The following is a description of a gene set: species: Mus musculus Human Gene Set: MEISSNER_BRAIN_HCP_WITH_H3K4ME3_AND_H3K27ME3 from publication Meissner A, Mikkelsen TS, Gu H, Wernig M, Hanna J, Sivachenko A, Zhang X, Bernstein BE, Nusbaum C, Jaffe DB, Gnirke A, Jaenisch R, Lander ES (PMID 18600261) DNA methylation is essential for normal development and has been implicated in many pathologies including cancer. Our knowledge about the genome-wide distribution of DNA methylation, how it changes during cellular differentiation and how it relates to histone methylation and other chromatin modifications in mammals remains limited. Here we report the generation and analysis of genome-scale DNA methylation profiles at nucleotide resolution in mammalian cells. Using high-throughput reduced representation bisulphite sequencing and single-molecule-based sequencing, we generated DNA methylation maps covering most CpG islands, and a representative sampling of conserved non-coding elements, transposons and other genomic features, for mouse embryonic stem cells, embryonic-stem-cell-derived and primary neural cells, and eight other primary tissues. Several key findings emerge from the data. First, DNA methylation patterns are better correlated with histone methylation patterns than with the underlying genome sequence context. Second, methylation of CpGs are dynamic epigenetic marks that undergo extensive changes during cellular differentiation, particularly in regulatory regions outside of core promoters. Third, analysis of embryonic-stem-cell-derived and primary cells reveals that 'weak' CpG islands associated with a specific set of developmentally regulated genes undergo aberrant hypermethylation during extended proliferation in vitro, in a pattern reminiscent of that reported in some primary tumours. More generally, the results establish reduced representation bisulphite sequencing as a powerful technology for epigenetic profiling of cell populations relevant to developmental biology, cancer and regenerative medicine. Genes with high-CpG-density promoters (HCP) bearing histone H3 dimethylation at K4 (H3K4me2) and trimethylation at K27 (H3K27me3) in brain., and this is the list of marker genes: TBX3, ROR2, SLC16A3, CDH22, OSR2 (odd-skipped related transciption factor 2), PCDH8, MOB3B, MAFB, DNAAF6, NPR3, HRH1, ASS1, MYO16, METRN, CPT1A, SLC7A2, HTR1B, FZD6, NTN4, EBF1, ANTXR2, TBX2, PAQR9, ITPKA (NCBI Gene Id 3706), SYNE3, HRH3, VAT1L, CHST8, SLCO5A1, SLC16A12, ECT2, MAL, AFAP1L2, TENM4, FOXD1, ANXA2, EN1 (engrailed homeobox 1), SLC25A13 (solute carrier family 25 member 13), ZIC5, SPIDR, NFE2L2, ADGRG6, SHISA2, IGDCC3, OPRD1, EDARADD, SYPL2, SOX18, ARHGAP11A, SMAGP, PRODH, SLC13A3, BMP6, IGFBP5, IGFBP4, TACR3, KIT, CXCL14, SP5, AMIGO2, DBX2, GJD2, GNAS, SHC4, IGFBP7, WNT10A, SLC25A21, LAMC2, CIMIP3, EGR2, SCN4B, CIMAP1B, SYT6, RCSD1 (RCSD domain containing 1), BUB1, NFIX, MLKL (mixed lineage kinase domain like pseudokinase), CBFB, SWAP70, MMP23B, TFCP2L1, HHEX, C1QL2, TWIST2, NEFH, TNFAIP8L3, CLDN5, SH3PXD2A, POPDC3, PLPP3, PAWR, PENK, PTPN14 (protein tyrosine phosphatase non-receptor type 14), CNN2, FGF5 (NCBI Gene Id 9192), IL17RB, RALYL, FGF11, ADAMTSL5 (NCBI Gene Id 339366), DPYSL5, RAP1GAP2, SALL3, VSIG10, GALNT6, TSKU, SELENOV, ADA, PLEKHF1, PAX3, EPB41L1, SLC9A3, GHSR, QRFPR, CAVIN1, SNX7, ARHGEF26, HLX, ACP7, VIM, SLC12A7, P2RX2, ADRA2A, NELL1 (NCBI Gene Id 4745), CRACR2B, RGS6, KIF18B, ID3, NKX1-2, GALR1, SHROOM3, PARP14, TENT5B, CPXM1, NKX3-1, SATB1, AP1M2, TPBG, NIFK, ASAP3, MDFIC, IRX5, NR4A2, SNX22, VIPR2, CDC42EP1, HS3ST2, GJB6, PAX6, CSPG4, BACE2, UTRN, IRS4, GLIS1, SMTNL2, GLIPR2, MAP3K6, FHDC1, FOXC1, PLTP, UBE2C, GJB2, CXADR, HES1, NFATC2, SEMA3F, LRRK1, ATP12A, SOX7, PTGER4 (prostaglandin E receptor 4), STXBP6, WRAP73, CARD10, GLI2, NTSR1, MOXD1, NEUROD2, ABT1, LY75, RGS7BP, KCNJ6, NRIP3, DCXR, SLC9A2, USP18 (ubiquitin specific peptidase 18), SLC16A9, ADAMTS15, GYPC, ATP1B1, EBF2, LIN7A, WNT6, SLC22A3, SDC1, TEAD4, GLDN, KCNK13, TC2N, PDE9A, GCH1, ITPR3, TXNIP, DLL3, KCNS3, GXYLT2, ABAT (NCBI Gene Id 731754), BFSP1, HHIP, ALOX12, PMP22, FREM2, LPCAT2, PROKR2, NOTUM, SVEP1, BOLL, SOX21, BARX2, BDNF, PPM1L, ANLN, PHLDB2, GNG13, IGF2BP2, HTRA1, SLC27A2, TBR1, KCNJ4, NHERF1, KCNF1, TCF7L2, SCIN, ACER2, KITLG, CCN1 (NCBI Gene Id 3491), CCND1, SNTB1, TES, TRIM36, SFI1, FOXF2, PODXL, NAPRT, OAF, DDIT4L, CCDC125, ID4, TMC6, SHISA6, COA6, PRDM8, IGSF21, ONECUT1, ZFP36L2, ISL2, PIF1, MTUS1, SCUBE2, DOCK1, COL26A1, CARTPT, SLC32A1, NEUROD1, FZD2, ECHDC2, TRIM47, DAB2, CPNE2 (NCBI Gene Id 8903), LITAF, THSD7B, PLCG2, MCUB, CCDC102A, A4GALT, ATOH8, RASSF7, RGS10, WWTR1, STAT5A, CBLN2, DOK1, MBNL3, DUSP10, GPR150, SNAI1, UNC5B, ASIC2, ITGA9, EBF3, DIPK1C, HK2, DYSF, KIAA1217, SORCS2, FGFR2, PTH2, AP1S3, MYB, EYA1, PODN, VAV2, CBS, N4BP3, C1orf115, PKDREJ, SYT2, HCN4, FAM110C, PDE4A, GFRA1, PROX1, LOXL4, NXN, LHFPL6, DLX1, CXCL16, NUAK2, EFNA5, ADRA1B, ASCL1, PIMREG, PDE5A (NCBI Gene Id 8654), KIRREL2, ATF3, DLC1 (DLC1 Rho GTPase activating protein), PPP1R1B, SEMA5B, EMILIN2, POU3F2, ABTB2, C1QTNF4, GAS1, CCNO, ST8SIA2, BCL2L11, FGFR3, ALS2CL, E2F2, CCBE1, ICAM5, WNT1, PDGFRA, PRKCZ, CH25H, TUBB6, FOXF1, ADRA1D, PTHLH, SLC43A1, TTK, GIPC3, ERICH2, GALR3, PRR5L, FBLN7, STK32A (serine/threonine kinase 32A), COL12A1, NXNL2, TGFB1, MLXIPL, GAB1, TSPAN12, DUSP4, DOCK8, JAG1, IL4R, PLEKHG3, SLC35D3, AREG, HS3ST3B1, CGNL1, VGF, STAC, PRSS12, SATB2, SLC4A4, RRM2, ZIC2, TMEM108, ITPRIPL2, CNIH3, AHNAK, KLK8, MCIDAS, KCNH8, RUNX1, RSPO2, IL17RD, NID2, ASCL2, COL27A1, ADRA2B, PXDC1, PTPRK, PIK3AP1, SDC4, CRTAC1, KDELR3, PLXNA4, AIF1L, FLVCR2, ACE, TRIL, VAMP5, NME2, SPRY4, FOXL2, RBPMS2, CMTM7, OLIG2, NEUROG2, KCNK6, BMP7, MBOAT1, PPM1J, KCTD1, STOM, CTSH, PRKCH, CHRNB2, NR2E1, GLIS3, ATP7B, BAG3, CNKSR3, RNF152, SYNGR3, PLEKHA2, PDLIM5, PLAG1, GRID2IP, AVPR1A, SULF2, PRKG1, RIPPLY3, SOWAHB, ITGA4, CRYBA2, PDLIM1, MTFR2, CD63, SGO1, GPC5, SALL1, GAD2, MKX, LHX2, KANK4, MMP28, TBX18, BCAR3, NPNT, ADORA2B, CRISPLD2, TUBA1C, PRRG4, PTPRB, ATP6V1C2, SLC16A10, EGFLAM, HIC1, GAD1, HEYL, PTPN5, NECTIN2, KCNQ2 (potassium voltage-gated channel subfamily Q member 2), IL17RA, CD24, HTR7, NFE2L3, KISS1R, NRG3, PIK3R5, PTPRU, GPRC5C, DAPK2, SCARA3, VAX1, HMCN1, CBLN4, PDE10A, RELN, ADAMTS8, ROR1, EGFR, CLIC5, TRIM14, NFIB, C6orf141, MFSD2A, NRARP (NOTCH regulated ankyrin repeat protein), THEMIS2, SLC6A11, PRKCQ, LTB4R2, ELFN1, ATP8B1, MARVELD3, SLC24A4, CCDC3, CASZ1, FLI1, PRSS23, LEF1, PDE1B, PTGER3, SOX1-OT, RAB11FIP1, SIX3, EFHD1, SCN5A (NCBI Gene Id 652341), ITGA5, UNC13B, C1QL1, ABTB3 (NCBI Gene Id 440109), OSMR, SLC29A4, MYCN, PPL, NDRG2 (NDRG family member 2), VSTM4, LAMA1, ACSF2, PRDM1, NPR1, C4orf19, INA, TRHDE, VIPR1 (vasoactive intestinal peptide receptor 1), SCUBE3, ABLIM3, NKX6-2, SYT13, ST14, KCNH3, FST, SLC1A3, EMB, CD302, CEMIP, ITGB5, NIBAN1, MCAM, KDR, MAL2, ADAMTS5, ARHGAP29, CSRP2, KCNK9, PPARA, CGAS, L3MBTL4, RGS9BP, CWH43, MOCOS, MAFF, DHRS3, OXTR, KCNA3, RHOC (NCBI Gene Id 389), ARX, TEC, ZNF804A, CMTM8, F3, PMAIP1, HS3ST6, ADGRE5, SCUBE1, WNT11, EIF4EBP1, WNT9A, B3GAT2, NXPH3, ADRB2, RET, EDN3, SYNGR2, CFAP206, RASGRF1, RNF220, DPP10, ARHGEF17, HTR2C, TSPAN18, SIGIRR, LOX, PKP2, GPR139, NTF3, KCNA7, HTR1F, MGAT5B, FUT4, SLC6A1, NKD2, EPHA2, SLC30A3, S1PR1, ANO5, TRIM58, PTGER2, TPM1, SLC30A10, CCN2, KCNK12, SLC39A8, TMEM37, NODAL, DMRTA2, CFAP299, SLC13A5, TBX15, FBXL7, TP53I11, MYO10, NTN1, CPNE7, CCDC88C, GREM1, FOSL1, TSPAN15, SEMA3C, LGR5, MDGA1, COLEC12, CDK18, DLL4, RPRM, HTRA4, SMO, ANO1, INHBB, EPHA3, TOP2A, KLHL14, WNK4, RBPMS, LDLRAP1, RERG, ZBTB7B, H1-5, TMEM63A, CD9, FOXP4, GPR83, FXYD6, BMP2, EGR3, P2RY1, PLOD2, HS3ST5 (heparan sulfate-glucosamine 3-sulfotransferase 5), CDCA7, WNT4, FHL3, E2F7, PTPN18, OTX2, PTGIS, PRLHR, MINAR1, MAP3K20 (mitogen-activated protein kinase kinase kinase 20), LMO1, KLF4, TICRR, STRIP2 (NCBI Gene Id 57464), CARHSP1, CDKN2B, SIX4, IL7, HCN1, ESRP2, KREMEN2, ADAMTS19, BAIAP2L1, UCN, PEAR1, SPSB4, TACSTD2, TIFA, HS3ST3A1, GIPC2, AFAP1L1, CLSPN, GPR26, SHROOM1, ZIC1, SYT14, UHRF1, MAF, SNX8 (NCBI Gene Id 29886), ADCY7, CACNG4, DLX5, CREB3L1, DRD5, SPON1, CABP7, SNX33, EVA1A, GRHL3, MYBL2, KLF2, NFATC1, ERBB3, GULP1, ARHGEF39, LTBR, CISH (NCBI Gene Id 29917), CBLN1, FIBCD1, PROS1, EMX1, PROK2, TMEM181, SEC31B, ASPM, GALNT3, PAQR5, SERTM1, PPP1R14A, WNT5A, NOG, EGR4, COL5A1, GLI3, KCNC3, LRP2, VSTM2B, FAT4, NOTCH1, NOX4, MSX1, CLDN11, SERPINE2, SCRT1, TAGLN2, CLDN23, INAVA, DTL, CDH13, NPY5R, PLK5, CCNA1, GSX1, ARHGAP27, ADORA2A, GPC3, IRAK3, CACNA2D2, SMC4, SLC26A4, LAMB1, ZIC3, NDRG1, KCNG3, FZD7, FZD10, ADAMTS17, C1QL3, HAPLN4, ALPL, SLC12A4, DMRT2, SVIL, MMP25, PPARGC1B, HAS3 (hyaluronan synthase 3), IER2, FRZB, ARG2, ADGRB2, SPC25, WIF1, MGARP, LYN, GNA14, ITGA7, PTCH2, DRD2, SHE, ERBIN, DOCK5, CDK1, SLC7A10, EMX2, CHST7, WNT7A, SIDT1, PDE3A, GLDC, LHX9, KLRG2, HSPA2, CERKL, CPNE9, MSX2, VSTM2L, IKZF1, RHBG, CDC14A, FOXJ1 (forkhead box J1), ATP10A, RSPO1, ADRA2C, KIF23, FGF19, PGM5, E2F8, TNS3, SFRP1, RAB3B, VDR, LRP5, UACA, KIF26B, GALNT14, KCNH1, EBF4, CDKN1C, TLL2, GNAL, MATN4, NTSR2, ITPKB, TUBB2B, CA4, ADGRV1, NIPAL4, ICOSLG, CD83, GRTP1, FAM181B, LAMC3, MAP3K21, THPO, DPP6, PSTPIP2, SLCO4C1, EVA1B, PLD5, ZFP36, AGPAT2, AJUBA, GCNT1 (NCBI Gene Id 2650), RASSF10, RRAS2, ADAMTS7, FZD5, RSPO3, PLPP2, NES, DLX2, SLCO2A1, SERINC2, NPTX2, PDGFD, TNFRSF10B, ADAP2, CHRNA5, ID2, DNAH11, SAPCD2, SMOC2, TCERG1L, ZBTB7C, SMAD6, S1PR3, FLT1, NDNF, SOX9, SFRP2, COL18A1, BVES, ERBB2, SHISAL2B, OLIG1, ZC3H12A, SLC4A11, PCDH17 (protocadherin 17), NGF, GRIK3, RPRML, SMOC1, DSG2, TRIM25, TMEM51, LYPD1, SLC6A17, PLLP, LEMD1, RIN3, ZNF536, SLC2A4, HJURP, SCNN1G (sodium channel epithelial 1 subunit gamma), LFNG, SFMBT2, GRIN2C (NCBI Gene Id 2905), PAPPA, TNFAIP8, TCF15, FGF9, SOX3, RRAD, ENPP1, TESC, CD248, SKAP2, PGF, P2RY2, GJD3, ITGA8, TRPM6, IRX3, BNC2, GATA6, CTDSP1, FIGN, VASH2, ST6GALNAC2, CORIN, PITX3, ESRRB, FN1, FBLN2, OTX1, LHFPL2, FRMD4B, EGLN3, PDLIM2, GJC1, NBL1, RASEF, DDAH2, PHLDA2, SOX1, B3GNT5, CLIC6, GDNF, FAM163A, ANKRD33B, EN2, ADAMTS18, SNTG2, C12orf56, KCNJ10, SASH1, NCAPH, BHLHA9, MYOCD, BATF3, ARHGAP10, CDH1, MEGF11, KCTD11, ZNF296, KCNH2, ZC3HAV1, GADD45B, NKX2-2, PERP, ADAMTS2, ISL1, ENTPD2, SNED1, IRX1, VSIR, IGFBP2, LPL, PRDM16, RAB20, SSTR1, NXPH4, P2RX5, ETNK2, LYZL4, TAP1, TGFB2, BHLHE22, OVOL2, CPNE5, CDKN2A, SP8 (Sp8 transcription factor), COCH, ZNF503, SHOX2, CCN3, SLC1A5, UCP2, SLC44A5, TRNP1, EMP2 (NCBI Gene Id 2013), SEZ6L, ZNF217, IRF8, EZR, SOWAHA, PROM1, PDE8A, LAD1, KCNJ8, TGFBR2, KANK1, FEZF2, TMEM151B, COL19A1, MECOM (MDS1 and EVI1 complex locus), OCLN, GPR88 (G protein-coupled receptor 88), TMEM163, TLL1 (tolloid like 1), MAPK12, DEPDC1B, PKIB, BMP3, MAST1, STK17B, CXCL12, COL15A1, TAFA2, TMEM98, HTR1A, ANKRD63, COPZ2, PPP1R3B, PDZRN3, F11R, EPAS1, RIPK4, DISC1, STAC2, S100A11, ONECUT2, CNNM1, PTPN3, RASGRF2, GATA2, HCRTR1, SP9, STIL, LLGL2, BCAN, PTPRO, THBD, DIRAS2, EYA4, CCKBR, IRF5, CLCF1, LGALS3, GUCY2D, PLPP4, CHRD, ABHD15, GRM8, SOX13, ALDH1A2, TRPM3, FOXQ1, OR2I1P, VWC2, GRHL2, LHFPL5, MYO5B, SNCAIP, CNTN2, C2CD4C, F2RL1, ESYT3, RBP4, MMP14, BIK, ARHGAP28, SOX2, CA10